Given this list of marker genes DPEP1, FOXO1, MMP3, GATA5, KCNC2, MAP3K5, CDK2, TRAF2, AIFM1, CCNA2, PTPN1, MTR, CRK, CFLAR, HNRNPD, AQP1, ATP5F1A, GUCY1B1, here is a description of the gene set: studied in species Homo sapiens Human Gene Set: GOBP_CELLULAR_RESPONSE_TO_REACTIVE_NITROGEN_SPECIES Any process that results in a change in state or activity of a cell (in terms of movement, secretion, enzyme production, gene expression, etc.) as a result of a reactive nitrogen species stimulus.